Given this list of marker genes HOXC8, CADM1, CADM3, AGO3, CDH10, AGO4, TNRC6A, CDH2, ACTG1 (NCBI Gene Id 71), CDH7, CDH6, ZEB2, CDH3, NECTIN3 (NCBI Gene Id 25945), TNRC6B, CDH18 (NCBI Gene Id 64404), CDH19, CDH17 (cadherin 17), ADAM33, BHLHE22, JUP, SP1, ACTB, TNRC6C, PVR (PVR cell adhesion molecule), CDH1, CDH5 (cadherin 5), CDH4, SOX10, ANGPTL4, ZC3H12A, MIR200C, CTNND1, CDH15, CDH13, PRDM8, NECTIN2, AGO2, AMOT, CDH11, HEYL, CDH9, CADM2, AGO1, SNAI1, AFDN, FOXF1, MOV10, CTNNA1, CDH24, CTNNB1, ANG, NECTIN4, CDH12, ILF3, NECTIN1, CDH8 (NCBI Gene Id 1006), ADAM19, here is a description of the gene set: Human Gene Set: REACTOME_ADHERENS_JUNCTIONS_INTERACTIONS studied in species Homo sapiens Adherens junctions interactions